Given this list of marker genes LYRM4, ISCU, HSCB (HscB mitochondrial iron-sulfur cluster cochaperone), FDXR, ISCA1, GLRX5, ISCA2, NFS1, FDX2, FXN, FDX1 (ferredoxin 1), SLC25A37, SLC25A28, here is a description of the gene set: species: Homo sapiens Human Gene Set: REACTOME_MITOCHONDRIAL_IRON_SULFUR_CLUSTER_BIOGENESIS Mitochondrial iron-sulfur cluster biogenesis